Given this list of marker genes Gmnn, Zfpm2, Akirin1, Smarca4 (NCBI Gene Id 20586), Cbfb, Ccdc62, Ruvbl1, Rrp1b, Zfp366, Sirt6, Trim37, Rnf20, Jund, Spen, Atn1, Bud31, Trim30c, Yeats2, Supt7l, Eny2, Med11, Wbp2nl (WBP2 N-terminal like), Raly, Trim13, Dmap1, Fhl2 (four and a half LIM domains 2), Muc1, Sap30, Taf15, Prkn, Ajuba, Cdyl, Med1, Trrap, Casp8ap2, Rxrb, Brd4, Ruvbl2, Crebbp, Kmt2d, Mrtfb, Dhrs7b, Ewsr1, Jazf1, Ccnd1, Mid2, Kdm5b, Ezh1, Tbl1x, Kat2a, Sfmbt1, Arid5a, Med26, Aebp2, Kdm4c, Sdr16c5, Med19, Mideas, Sertad1, Uxt, Ncoa3, Tada2a, Med30, Parp10, Atf7ip2, Trim30a, Thrap3, Zmynd11, Birc2, Nr3c1, Arrb1, Nab2, Ncoa7, Ascc1 (NCBI Gene Id 69090), Ing4, Ski, Wnt3a, Lcor, Ss18l1, Hdac9, Zmiz1, Trim32, Ctbp2, Sfmbt2, Lmo4, Hmga1, Pias4, Tob2, Map3k10, Dhx9, Snw1, Nipbl (NIPBL cohesin loading factor), Tsc22d1, Pprc1, Tcerg1l, Tcp10a, Xpc, Trim30b, Med16, Zfp354b, Ezh2, N4bp2l2, Parp14, Sub1, Bhlhe41, Ncoa6, Parp9 (NCBI Gene Id 80285), Arid3a, Rcor3, Pdlim1, Tle3, Hspa1a, Tcp10c, Wwox, Park7, Smarcd3, Ccdc124, Ddx5, Hipk3, Acss2, Rbm14, Actn1, Nkx2-1, Usp22 (NCBI Gene Id 216825), Hif1an, Trim5, Pou2af3, Eid2, Hdac3, Prkcb, Nrbf2, Phf12, Arglu1, Cbfa2t2, Med9, Id4, Carm1, Ptpn14 (protein tyrosine phosphatase, non-receptor type 14), Btaf1, Zxdc, Id1, Kat8, Sap18, Lmo1, Dcaf6, Mta2, Med12l, Brd7, Kat7, Per2, Sin3a, Trp53bp1, Ldb2, Med12, Mycbp, Kmt2c, Zfp747, Hcfc1, Rcor2, Pou2af2, Myt1l (NCBI Gene Id 73066), Pa2g4, Trim28, Pkn1, Asah1, Tle2, Brd8, Trim52, Crtc1, Trim25, Med27, Camta2, Irf4, Rcor1, Zfp764l1, Hmga2, Tle5, Cnot6, Elk1, Cd274, Bmal1, Yap1, Ddit3, Taf5l, Bcor, Ark2n, Ctnnb1, Daxx, Ube3a, Trim27, Smarcd2, Trib3 (tribbles pseudokinase 3), Hsbp1l1 (heat shock factor binding protein 1-like 1), Tdrd3, Trim62, Fhl3, Irf2bp2, Bcl9l, Hdac7, Phf8, Uri1, Ube2l3, Mecp2, Kat6a, Cited4, Trim8, Arid5b, Nupr1, Npm1, Med20, Pcbd1, C1qbp, Kat6b, Pml (promyelocytic leukemia), Eid1, Dnmt3b, Med22, Zmiz2 (NCBI Gene Id 97766), Psmc3ip, Jmjd1c, C1d, Slc30a9, Wnt4, Gon4l, Scai, Myocd, Rere, Tcerg1, Taf6, Gps2, Tgfb1i1, Hyal2, Ankrd1 (NCBI Gene Id 12907), Ets1, Kdm1a, Mak, Cenpj, Tfap2a, Nme2, Cmtm2a, Taf9, Trim24, Tox2, Pmf1, Taf12, Zxdb, Cited2, Cnot9, Zfpm1, Hr, Asxl1, Sap30l, Pex14, Tob1, Pus1, Npat, Mta1, Ldb1, Lmo3, Mta3, Ifi204, Yaf2, Bcl3, Pias3, Nr0b1 (NCBI Gene Id 11614), Fus, Mlip, Hdac4, Med29, Phb1, Smyd1, Cdyl2, Smad7, Hipk1, Trim14, Maml2, Dnajb1, Med10, Smarcb1, Mier3, Supt3, Tada3, Notch1, Kdm2b, Tcf4, Taf11, Hmgb1, Med21, Lpin1, Bcl9, Tada2b, Cdca4, Bclaf3, Bcl11a, Pbxip1, Kdm5a, Bcorl1, Noc2l, Kctd1, Fiz1, Cbfa2t3, Crym, Niban2, Tcp10b, Sra1, Tle1, Tbl1xr1, Ctbp1 (C-terminal binding protein 1), Wtip, Wdr77, Kmt2e, Mamstr, Tsg101, Ppargc1b, Rbfox2, Pou2af1, Phf2, Trip4, Med18, Mms19, Actn4, Rap2c, Hmgb2, Trim38, Med4, Rbpms, Tox3, Kmt5a, Psmd9, Calcoco1, Med14 (NCBI Gene Id 72974), Taf6l, Trim12c, Fgf2, Pir, Ep300, Hsbp1, Kat5, Jup, Psip1, Mier2, Id2, Sin3b, Nr0b2, Zmynd8, Lpxn, Naca, Basp1, Kat2b, Usp16 (NCBI Gene Id 76164), Ncor2, Sfr1, Lpin2, Trim31, Kctd15, Dyrk1b, Crtc2, Trim21, Prpf6, Runx1t1, Ddx54, Zfp764, Lmo2, Ccar1, Maged1 (MAGE family member D1), Pkm, Brca1, Bclaf1, Ncoa1, Maml3, Hcfc2, Med13l, Id3, Wwc1, Kdm7a (lysine (K)-specific demethylase 7A), Aip, Riox2, Med7, Tle7, Tcf25, Actn2, Zfp451 (NCBI Gene Id 98403), Dcc, Eno1, Hdgf, Setd5, Smarca2, Tacc1, Usp21, Mier1, Kdm3b, Kdm3a, Zfp541, Dot1l, Cebpz, Camta1, Lpin3 (lipin 3), Irf2bp1, Trim15 (NCBI Gene Id 69097), Utf1, Hdac5, Cnot7, Setd4, Nrip1 (nuclear receptor interacting protein 1), Kdm2a, Nfkb1, Gsdmd, Cir1, Fbxl19 (NCBI Gene Id 233902), Chd4, Wbp2, Bcl10, Mybbp1a, Zfp653, Jade1, Edf1, Med31, Drap1, Ppargc1a, Tdg, Qki, Wwtr1, Pias1, Ssbp3, Tle6, Eno1b, Hmga1b, Ddx1, Akirin2, Btg2, Hipk2, Insm2, Atxn7l3, Nab1, Rbbp8 (retinoblastoma binding protein 8, endonuclease), Apex1, Prdm16, Vgll2, Nucks1 (nuclear casein kinase and cyclin-dependent kinase substrate 1, NCBI Gene Id 98415), Hnrnpu, Foxp3, Trim30d, Cops5, Med15, Atf7ip, Fhl5, Prdm8, Med8, Tada1, Cops2, Mtdh, Pias2, Med24, Med13, Sirt1, Nup98, Nsd1, Flywch1, Med6, Ddx17, Phf24, Jmy, Zic3, Mrtfa, Zcchc12, Zfp747l1, Smarcd1, Crtc3, Ncor1, Irf2bpl, Ss18, Rybp, Bend6, Sertad2, Elob, Prmt2, Maml1, Arl2bp, Dyrk1a, Med17, Tcf20, Elane, Hdac1, Ncoa2, Supt20, Zbtb32, Prmt5, Nfkbiz, Cys1, Rad54l2, Nrg1 (NCBI Gene Id 320603), Tle4, Mysm1, Sqstm1, Limd1, Trerf1, Cited1, Eid2b, Lmcd1, Setd3, Trim12a, Tmf1, Phf10, here is a description of the gene set: A transcription regulator activity that modulates the transcription of specific gene sets via binding to a DNA-binding transcription factor at a specific genomic locus, either on its own or as part of a complex. Coregulators often act by altering chromatin structure and modifications. For example, one class of transcription coregulators modifies chromatin structure through covalent modification of histones. A second class remodels the conformation of chromatin in an ATP-dependent fashion. A third class modulates interactions of DNA-bound DNA-binding transcription factors with other transcription coregulators. Mouse Gene Set: GOMF_TRANSCRIPTION_COREGULATOR_ACTIVITY species: Mus musculus